Given this list of marker genes CLSTN3 (calsyntenin 3), SEMA3A, NRP1, NRP2, S100B, SEMA3F, here is a description of the gene set: Long distance growth of a single sympathetic neuron projection involved in cellular development. A neuron projection is a prolongation or process extending from a nerve cell, e.g. an axon or dendrite. species: Homo sapiens Human Gene Set: GOBP_SYMPATHETIC_NEURON_PROJECTION_EXTENSION